The following is a description of a gene set: Human Gene Set: WP_CONSTITUTIVE_ANDROSTANE_RECEPTOR_PATHWAY studied in species Homo sapiens Constitutive androstane receptor pathway, and this is the list of marker genes: UGT1A4, DNAJC7, CYP3A4, CYP4A11, SULT1A1, ABCC2, NR1I3, NCOA1, ABCC3 (ATP binding cassette subfamily C member 3), RXRA, NCOA2, CYP2C9, PTPA (protein phosphatase 2 phosphatase activator), UGT1A9, CYP2B6, GSTA2, CYP3A5, CYP2C19, PPARGC1A, CYP2A6, NCOA6, SP1, FOXO1, HSP90AA1, EHHADH, ABCB1, SMC1A, SULT2A1, ALAS1, UGT1A6, UGT1A1